The following is a description of a gene set: Mouse Gene Set: MIR_5623_5P Genes predicted to be targets of miRBase v22 microRNA mmu_miR_5623_5p in miRDB v6.0 with MirTarget v4 prediction scores > 80 (high confidence targets). species: Mus musculus from publication Chen Y, Wang X (PMID 31504780), and this is the list of marker genes: Rab7, Patl1, Setbp1, Tmem255a, Tmem183a, Mapk3, Kng1, Dmtf1, Zmiz1, Ash1l, Hycc2, Styk1, Nr2c2, Galnt7, Mfap4, Pakap, Trim33, H2bc23, Proz, Celf6, Prx, Hephl1, Fgf9, Nrf1, Zfp341, Arih2, Slc9a6, Myo5a, Cluh, Slc25a31, Nrip3, Gpd2, Pgrmc2, Slc4a4 (NCBI Gene Id 54403), 4933402D24Rik, Tspan5, Erbb4, Ralgapa1, Cadps2, Myt1l (NCBI Gene Id 73066), Prkg1 (NCBI Gene Id 381235), Clcc1, Astn1, Tmem104, Paip2, Hbs1l, Sh3bgrl2, Cdc14b, Dkc1, Lin28b, Mtfr1l, Ezh2, Akap13, Nat8l, Gjc3, Carm1, Rasa3, Slc1a4, Rarg, Ifit2, Rabgap1, Snx24, Rhbdf1, Nectin1, Anks1, Stox2, Pacs2, Kctd7, Nav1, Itk, Rgs12, Gdpd5, Tmprss11f, Mical3, Rapgef6, Chmp1b, Rbm5, Cxcr3, Agrn, Vapb, Wfikkn2 (WAP, follistatin/kazal, immunoglobulin, kunitz and netrin domain containing 2), Sh3pxd2a, Gm5544, Dip2b, Kcnq2 (potassium voltage-gated channel, subfamily Q, member 2), Ntng1, Pacsin1, Olfm1, Otop3, Pfn1, Sntg1, Slc4a8, Sos1 (NCBI Gene Id 70778), Msmo1, Cxxc5, Csnk1d, Rnf169, Rai14, Spg7, Veph1, Mex3c, Fbxo33, Slc39a13, Ldlrap1, Trim3, Marchf8, Tbl1xr1, Srsf6, Crkl, Eeig1, Suds3, Rcor2, Qser1, Zfp704, Ccdc85a, Cacnb2, Ttbk2, Adora2a, H2bc24, Nr6a1 (NCBI Gene Id 76667, nuclear receptor subfamily 6, group A, member 1), Eci1, Edem3, Zfp41, Diaph1, Zfp418, Tfdp1, Grin3a, Lamp1, Cep57, Grk6 (NCBI Gene Id 26385), Cdk6, Spn, Zmym3, Usp54, Atp1a2, Zyx, Hnrnpdl, Zcchc24, Zc3h11a, Ankdd1b, Enoph1, Cnot6l, Hmgxb4, Rgs17, Ndst1, Shank2, Socs6, E2f3, Rgs8, Skint3, Ppp1r16b, Dnajb12, Pcdhb3, Ppp2r2b, Gnpnat1, Parp16